The following is a description of a gene set: from publication Burton GR, Guan Y, Nagarajan R, McGehee RE Jr (PMID 12137940) Human Gene Set: BURTON_ADIPOGENESIS_PEAK_AT_8HR The molecular mechanisms that regulate cellular differentiation during development and throughout life are complex. It is now recognized that precise patterns of differentially expressed genes ultimately direct a particular cell toward a given lineage and many of these are regulated during the earliest stages of differentiation. Using a microarray-based expression analysis, we have examined gene expression profiles during the first 24 h of 3T3-L1 adipocyte differentiation. RNA was isolated at times 0, 2, 8, 16, and 24 h following stimulation of differentiation and hybridized in duplicate to high density Affymetrix microarray gene chips containing a series of 13,179 cDNA/expressed sequence tag (EST) probe sets. Two hundred and eighty-five cDNA/ESTs were shown to have at least a fivefold change in expression levels during this time course and both hierarchical and self-organizing map clustering analysis was performed to categorize them by expression profiles. Several genes known to be regulated during this time period were confirmed and Western blot analysis of the proteins encoded by some of the identified genes revealed expression profiles similar to their mRNA counterparts. As expected, many of the genes identified have not been examined in such a critical time period during adipogenesis and may well represent novel adipogenic mediators. species: Mus musculus Cluster 3: genes maximally expressed at 8 hr time point during differentiation of 3T3-L1 fibroblasts into adipocytes in response to adipogenic hormones., and this is the list of marker genes: CD44, HMGA2, ITGA5, XPO1, FGL2, TUBB2A, BZW1, PYHIN1, TSC22D3, TIAM1 (NCBI Gene Id 7074), UCP2, SRXN1, POR, SDC1, SLC23A2, RRAS2, PLAC8, PRR5, PRDX6, IL1RL1, TOP1, HSPH1, FOSL1, SLC7A6, ARL4D, GSTO1, EREG, UAP1, SAMHD1, RCL1, VDR, KLF5, SCD, NOP56, SLC16A1, PPA1, CEBPB, PPP1R2, TEAD4